The following is a description of a gene set: Mouse Gene Set: GOBP_TISSUE_REGENERATION species: Mus musculus The regrowth of lost or destroyed tissues., and this is the list of marker genes: Spaar, Gata4, Myoz1, Capn3 (NCBI Gene Id 98918), Myf6, Vps54, Gjd4, Igsf10, Ppard, Serpine1, Akirin1, Cd81, Dusp10, Mir682 (microRNA 682), Cdkn1a, Klf5, Gm34220, Ninj2, Gap43, B4galnt2, Sox15, Nanog, Gnat1, Ezh2, Fbxw10, Tarbp2, 9630013A20Rik, Fzd7, Notch1, Xirp1, Wnt7a, Postn, Wnt10b, Adam15, Fgf10, Selenon, Mir675, Cdkn1b, Cflar, Kpna1, Gnat2, Ccn3 (cellular communication network factor 3), Cd9, Pax7, Lgr6, Ptgfrn, Eppk1, Ptpn12, Apoa5, Igfbp1, Plg, Yap1, Synb, Apod, Nfix, Sox2, Gja1, Dysf, Ninj1, Anxa1, Mir489, Mtpn, Bcl9, Hdgfl2, Ifrd1, Snhg15, Mustn1, Mcub, Igf1, Sgca, Dicer1, Mymx, Mymk, P2rx5, Plau, Fkrp, Dag1, Mdk, Pkm, Tmem182, Cpq, Ascl3, Ptn, Myod1, Fzd9, Large1, Hopx, Col6a1, Erbb4, Dmd, Mstn, Bin3, Gpx1